Given this list of marker genes HACL1, SLC27A2, PHYH, HAO1, PEX13, ILVBL, SLC25A17, here is a description of the gene set: species: Homo sapiens Human Gene Set: GOBP_FATTY_ACID_ALPHA_OXIDATION A metabolic pathway by which 3-methyl branched fatty acids are degraded. These compounds are not degraded by the normal peroxisomal beta-oxidation pathway, because the 3-methyl blocks the dehydrogenation of the hydroxyl group by hydroxyacyl-CoA dehydrogenase. The 3-methyl branched fatty acid is converted in several steps to pristenic acid, which can then feed into the beta-oxidative pathway.